The following is a description of a gene set: species: Homo sapiens Abnormal rise and fall of the voice in speech and vocalization for the context and cultural situation. Human Gene Set: HP_ABNORMAL_INTONATION Abnormal Intonation, and this is the list of marker genes: SRPX2, GIGYF2, MFN2, SMC3, CHRNB1, MTX2, NSD1, ERCC4, SMARCAL1, AR, RIN2, GBA1, MORC2, WRN, CFL2, ARID1B, SYT2, SEC24D, VPS35, DNAJC13, RAD21, TTN, SELENON, ADAMTSL2, NSUN2, IGF1R, TRIM37, SUZ12, GRB10, LRRK2, MYH7, XRCC4, STAT5B, FBXO7, BSCL2, ZMPSTE24, TAF6, FAM111A, CWF19L1 (NCBI Gene Id 55280), LMNA, CTNND2, PPP1R15B, POLD1, SERPINH1, TRMT10A, LIG4, NIPBL, GRIN2A, HSPG2, EZH2, P4HB, RBBP8, TRPS1, MDM2, HDAC8, SEMA5A (semaphorin 5A), ITPA, NBAS, GHR, FMR1, PCNT (NCBI Gene Id 9346), SMC1A, SRCAP, POC1A, SNCA, BLM, BRD4, MED12, ORC4, EIF4G1